The following is a description of a gene set: Human Gene Set: HP_APLASIA_HYPOPLASIA_OF_THE_INNER_EAR Aplasia/Hypoplasia of the inner ear Aplasia or developmental hypoplasia of the inner ear. studied in species Homo sapiens, and this is the list of marker genes: FGF3, GREB1L, NEUROG1, FOXI1, DDX11, FOXP2, EYA1, SIX1, SIX5, SLC26A4, KCNJ10